Given this list of marker genes Igfbp3, Ghr (NCBI Gene Id 223275), Rapgef4, Sri, Pfkl, Slc5a5, Bmpr1b, Tiparp, Sirt6, Igf2, Chga, Gata3, Kiss1 (KiSS-1 metastasis-suppressor), Slc17a4, Foxd1, Ppp3ca, Pfkfb2, Il1rn, Osbp, Akr1c21, Pax8, Bco2, Cacna1a, Akr1d1, Fbn1, Tcirg1, Npvf, Atg7, Kiss1r, Akr1b1, Ywhaz, Cask, Chrm3 (cholinergic receptor, muscarinic 3, cardiac), Por, Cckbr, Rph3al, Prmt3 (NCBI Gene Id 71974), Lcn5, Tunar, Tiam1, Hsd17b7, Wnk4, Clcn2, Cftr, Hsp90b1, Abcb1a, Mtnr1b, Inha, Pde8b, Akr1cl, Hcar2, Ace2, Enpp1, Adora1, Prkaca, Kdm5b, Cplx1, Myt1, Adh1, Tacr2, Il1b, Crhr2, Cyp1b1, Aldh8a1, Foxl2, Duox2, Yipf5, Birc5, Pnlip, Sdr9c7, Dhrs7, G6pc2, Aldh1a3, Corin, Snord34, Sox8, Acsl4, Cartpt, Sult2a2, Lep, Slc39a14, Rab3a, 2610005L07Rik, Sult2a6, Crhr1, Mcu, Hsd17b11, Srebf1, Snap23, Eipr1, Trh, Bcat2, Rdh14, Hif1a, Foxo1, Mup3, Gipr, Fam3d, Eny2, Kcnq1, Rest (NCBI Gene Id 72127), Cyp2j5, Sult2a1, Adcyap1, Ugt1a7c, Ucp2, Zbed6, Nmu, Ero1b (NCBI Gene Id 73439), Lrrc8a, Hmga2, Hsd17b3, Hmgcr, Fgfr4, Selenot, Pde3b, Pdgfra, Hpn (NCBI Gene Id 15451), Casr, Adm, Abat, Slc7a8, Ugt1a1, Slc9b2, Sfrp1, Sox11, Slc18a2 (NCBI Gene Id 68754), Snx19, Rfx6, Cdk16, Tardbp, Kcnb1, Hmgn3, Trpm5 (transient receptor potential cation channel, subfamily M, member 5), Retsat, Pex5l, Cyp3a41b, Zmpste24, Spp1, Egr1, Nos2 (NCBI Gene Id 18126), Ren1, P4hb, Cacna1e, Adh6b, Rdh8 (NCBI Gene Id 235033), Slc7a5 (solute carrier family 7 (cationic amino acid transporter, y+ system), member 5), Aimp1, Crh (NCBI Gene Id 383938), Fzd4, Aldh1a7, Nadk, Hsd17b10, Doc2b, Cyp11b2, Cyp26a1, Irs1, Anpep, Ghsr, Ppp3cb, Ugt2b1, Ucn, Cyp3a41a (NCBI Gene Id 53973), Nrg1, Ghrhr, Akr1c14, Bglap2, Ddo, Ppargc1a, Nr0b2, Nr3c1, Lyn, Cyb5r4, Myh9, Nmb, Ffar2, Rdh9, Kcnma1, Adh4, Cyp3a11, Igf1r, Gcnt4, Mc4r (melanocortin 4 receptor), Chst10, Acvr2b, Aanat, Dgat2, Dhrs11, Efna5, Tubb1, Srd5a2 (NCBI Gene Id 94224), Bmp6, Ces1d, Klf7, Anxa5, Stat5b (signal transducer and activator of transcription 5B), Klf9, Cyp3a44, Ptprn2, Rptor, Raf1, Furin, C1qtnf3, Hnf1a (HNF1 homeobox A), Sirt3, Nell2 (NEL-like 2), Hnf1b, Ffar3, Rab1a, Rdh10, Myrip (myosin VIIA and Rab interacting protein), Stxbp4 (NCBI Gene Id 320264), Nnat, Hsd17b6, Egfr, Mup11, Sin3a, F2rl1, Rab11fip3, Rdh13, Stx4a, Ces2a, Dynll1, Psg18, Sytl4, Lipe, Nr5a1, Slco1c1, Akr1c6, Ide, Cpt1a, Hfe, Plb1, Sult1a1, Snord33 (NCBI Gene Id 27208), Prkce, Oprk1, Hsd3b9, Asmt, Epha5, Igf1, Cyp2d22, Tspo, Sult1e1, Slco4a1, Disp1, Fgfr1, Prkar1a, Duoxa2 (NCBI Gene Id 66811), Cpa3, Adcy8, Pcsk4, Naglu, Cyp2w1, Sult1b1, Fgf23, Bad, Sirt1, Anxa7, Tbc1d1, Sidt2, Cplx3, Mlxipl, Tcf7l2, Anxa1, P2ry1, Creb1, Cltrn, Tac1, Dio2, Hsd17b2, Cyp1a2, Nppa, Mep1a, Adipoq, Stxbp5l, Dgat1, Cyp26c1, Ltbp4, Cyp21a1, Agt, Sybu, Serpina7, Papss2, Ffar1, Trpv6, Vip, Ensa, Bmal1, Mup1, Slc8b1, Ffar4 (NCBI Gene Id 209389), Galr1, F2rl2, Gja1, Dhrs3, Abca12, Gip, Sstr5, Afp (NCBI Gene Id 11576), Syt9, Reln, Akr1c13, Acvr1c, Cyp26b1, Strap, Grp, Stard3, Arhgef7, Snord35a, Tnf, Jak2, Sult2a8, Ptprv, Il11, Sirt4, Neurod1, Schip1, Nucb2, Tg, Iyd, Mup4, Piwil4 (NCBI Gene Id 330890), Sult2a4, Rpe65, Slc2a2, Pck2, Foxa1, Aqp1, Ces1e, Pclo, Cyp17a1, Plcb1, Mpc2, Cd38, Pparg, Srd5a1, Hsd17b1, Chd7, Slc30a5, Inhba, Pcsk6, Ncoa6, Ildr1, Gfi1, Ces1f, Ano1, Fgb, Ugt2b35, Atp1a1, Tm7sf3, Duoxa1, Kcnj11, Pcsk5, Bmp2, Lepr, Fga, Fdx1, Nkx3-1, Chst8, Clcf1, Glul, Rab11b, Pcsk1n (NCBI Gene Id 30052), Nr1h4 (NCBI Gene Id 20186), Mir130a (NCBI Gene Id 387149), Tpo, Htr2c, Oxct1, Hsd17b12, Star, Clock, Rasl10b, Gpr27, Myb, Prkcb, Oga, Ednrb, Ucn3, Lif, Rbp4 (NCBI Gene Id 19662), Vsnl1, Dgkq, Itsn1, Glud1, Kif5b, Dkk3, Foxe1, Cyp11b1, Slc16a10, Lrp5, Adora3, Vamp2, Cyp11a1, Pcsk2, Gnaz, Rims2, Akr1c19, Smad4, Adra2a, Smad2, Pask, Abcc8, Scp2, Nr1d1, Gdf9, Fkbp1b, Eef1ece2, Brsk2, Ptpn11, Sult2a7, Ins2, Ifng, Osm, Trpv4, Ptger3, Ctns, Ghrl, Ptger4, Hsd3b1, Vamp8, Cyp2c55, Gnas, Ptpmt1, Pim3, Hsd3b4, Akr1c20, Kcnk9, Cyp19a1, Syt7, Gprc6a, Ccdc186, Gal, Glp1r, Esr1, Shh, Rdh1, Ndst2, Map4k4, Gnaq, Blk, Agtr2, Ece1, Tbx3, Lrat, Prep, Nfkb1, Ces2c, Inhbb, Uts2, Fam3a, Bco1, Sox4, Hsd3b6, Cacna1h, Rbm4, Btk, Comt, Abcc2, Safb, Mup5, Trpa1, Pla2g3, Itpr1, Tfr2, Pde1c, Rab11fip2, Cela2a, Akr1c18, Cyp27b1, Snord32a, Nlgn2, Sult2a5, Pcsk1, Cry1, Mup2, Cyp3a16, Rdh16 (NCBI Gene Id 19683), Gm2044, Ugt2b5, Npy1r, Ctsb, Trpm4, Ptbp1, Hid1, Hadh, Pnpla2, Selenom, Mme, Il6, Plekha1, Prlhr, Ucn2, Bmp5, Rfx3, Apln, Midn, Gnao1, Oprm1, Prcp, Atp6ap2, Kcnn4, Isl1, Cry2, Stub1, Stxbp3, Gpr119, Jagn1, Ube2q1, Ptprn, Trpm2, Cpa4, Mafa, Baiap3, Dhrs4, Enpep, Aldh1a2, Ildr2, F2 (coagulation factor II), Hnf4a, Rbp1, Scg5, Med1, Il4i1, Fgg, Rdh11, Cyp1a1, Foxa2, Madd, Sct, Smpd3, Nkx6-1, Pick1, Alox5, Rdh19, Tnfsf11, Fshr, Ugt2b36, Sdr16c5, Hcfc1, Aldh1a1, Edn2, Irs2 (NCBI Gene Id 384783), Gh, Cyp46a1, Rdh7, H6pd, Ecrg4, Ppard (NCBI Gene Id 69050), Edn3, Scnn1b, Bbs1, Sp1, Hmga1, Akr1c12, Gnb3, Niban2, Cntf, Stx1a, Retn (resistin), Slc25a22, Serp1 (NCBI Gene Id 28146), Camk2n1, Hsd3b2, Pomc, Cnr1, Cpe, Kalrn (NCBI Gene Id 72378), Cckar, Gcg, Cyp27a1, Tacr1, Fam3b (FAM3 metabolism regulating signaling molecule B), Pfkm, Lrp1, Ccl5, Gnai1, Wnt4, Htr1a, Abcg1, Dab2, Gck (NCBI Gene Id 14624), Ccn3, Gpr39, Rab44, Rac1, Lhcgr, Rdh5, Cpq, Nr5a2, Uqcc2, Rab11fip5, Awat2 (acyl-CoA wax alcohol acyltransferase 2), Gpr68, Pla2g6, Slc26a7, Tmf1, Cga, C1qtnf1, Slc16a1, Hsd17b8, Sult2a3, Ace (NCBI Gene Id 11421), Hsd3b3, Adh6a, Hsd3b8, Stim1, Ctsl, Rdh16f2, Gabbr1, Arrb1, Cacna1c, Adh7, Htt, Crhbp, Capn10, Vgf, Nos1, Runx1, Hsd3b5, Dio3, Slc16a2, Rdh12, Mir205hg, Orai1, Mtnr1a, Scarb1, Mfn2, Aacs, Crabp2, Cacna1d, Snap25, Stc2, Dhrs9, Exoc3l, Npff, Per2, Fto, Vdr, Pde4c, Mir410, Slc30a8, Mcpt4, Prkn, Ces2e, Park7, Gper1 (NCBI Gene Id 76854), Adcy5, C1qtnf12, Mir200a, Ghrh, Myo5a, C2cd2l, Ndufaf2, Gna11, Drd2, Trpc1, Edn1, Snx4, Arnt, Psmd9, Ctsk, Gpld1, Rab8b, Hsd17b4, Slc3a2, Hsd11b1, Ece2, Prkd1, Tfap2b, Cyp2s1, Sgpl1, Pdx1, Crym, Kcnj6, Dio1, Adam10, Acvr2a, Agtr1a (NCBI Gene Id 72294), Rab11fip1, here is a description of the gene set: Mouse Gene Set: GOBP_REGULATION_OF_HORMONE_LEVELS Any process that modulates the levels of hormone within an organism or a tissue. A hormone is any substance formed in very small amounts in one specialized organ or group of cells and carried (sometimes in the bloodstream) to another organ or group of cells in the same organism, upon which it has a specific regulatory action. species: Mus musculus